Given this list of marker genes Kcnj15, Cngb1, Hcn3, Ano1, Gria3, P2rx7, Asic4, Kcnh7, Chrna6, Htr3a, Bnip1, Kcnj12, P2rx1, P2rx5, Chrnd, Hcn1, Kcnj2, Cnga1, Trpm2, Catsper4, Kcnj1, Tpcn1, Ryr3, Tmem38a, Kcnn2, Kcnn1, Itpr1, Chrna3, Chrna10, Grin2b, Pkd2, Asic2, Grin1, Tpcn2, Gria1, Asic1, Chrna2, Grik4, Kcnj16, Best2, Chrna7, Kcnu1, Itpr2, Kcne2, Ccdc51, Chrng, Tmem63b, Kcnj4, P2rx4, Chrna4, Grik2, Kcnn4, Chrne, Cnga4, Ano10, Kcnmb3, Gria2, Catsper1, Chrnb4, Trpa1, Kcnj11 (NCBI Gene Id 16514), Grin2a, Trpm5, Cav1, Hcn4, Trpv1 (NCBI Gene Id 22366), Kcnj9, Calhm1, Itpr3, Ryr1, Mcoln3, Htr3b, Grin2d, Asic3, P2rx3, Tmem63c, Kcnj3, Kcnh6, Catsper2, Kcnt2, Pkd2l1, Kcnj13, Aqp1, Mcoln2, Chrna5, P2rx6, Kcnj5, Kcnh3, Hcn2, Kcnj8, Kcnmb1, Trpm8, Cngb3, Kcnmb2, Rasa3 (NCBI Gene Id 97473), Chrnb2, Cnga2, Grik1, Kcnj6, Pex5l, Kcnn3, Trpc3, Kcnt1, Cnga3, Chrnb1, Kcnh2, Chrna9, Ano6, Kcnj14, Trpm4, Scnn1g (NCBI Gene Id 20278), Grik3, P2rx2, Mcoln1, Kcnmb4, Tmem63a, Asic5, Grik5, Ryr2, Kcnj10, Grin2c, Scnn1a, Kcnk18, Chrnb3, Pkd1l3, Chrna1, Kcnma1, Kcnk1, Scnn1b, here is a description of the gene set: Mouse Gene Set: GOMF_LIGAND_GATED_MONOATOMIC_CATION_CHANNEL_ACTIVITY studied in species Mus musculus Enables the transmembrane transfer of an inorganic cation by a channel that opens when a specific ligand has been bound by the channel complex or one of its constituent parts.